Given this list of marker genes Pla2g4c, Lpcat2, Pla2g5, Chpt1, Pla2g4a, here is a description of the gene set: studied in species Mus musculus The chemical reactions and pathways resulting in the formation of platelet activating factor, 1-O-alkyl-2-acetyl-sn-glycerol 3-phosphocholine, where alkyl = hexadecyl or octadecyl. Platelet activating factor is an inflammatory mediator released from a variety of cells in response to various stimuli. Mouse Gene Set: GOBP_PLATELET_ACTIVATING_FACTOR_BIOSYNTHETIC_PROCESS